Given this list of marker genes TECPR1, ALPK3, MFSD3, ERAL1, H1-2, DYRK2, AIRN, PEMT, DRC3, VIPR1, MTG1, ADCY6, C8orf58, TAF3, HID1, ATXN7L3, CD96, UNC5CL, CYP2D6, SRSF2, RESF1, CHTOP, ARHGEF1, ECM1, CPM, POGZ, GUCY1A1, SRSF12, RNF187, CD86, RNPC3, CPSF6, OAS2, NOTCH4, PDE1B, CISH, C19orf38, CLIC5, CRIPTO, STX1A, OTULINL, PYROXD2, RPS6KA1, RSRP1, GALNT10, UBXN11, KLHL41, NCF1, RCN3, BRD9, TSHZ1, GUCD1 (NCBI Gene Id 83606), NMNAT2 (NCBI Gene Id 23057), ARHGAP9, LYRM7, DNASE1, RASA3, ATG4C, IMP3, REV1, TTYH3, AQR, ZNF629, FAM98C (family with sequence similarity 98 member C), EPB41L1, SBK1, ETV3, TCFL5, BRME1, UST, MYOM1, EYA2, MAGEF1, TPPP, TACC2, SEZ6L2, FCGRT, ZNF764, IMPDH1, ENGASE, KAZALD1, CD5, CA2, USP36, ADD1, BMP5, CRY1, CLDN10, ILDR1, RCBTB2, SPEF2, SETX, GLT8D2, TRAF4, ALDH2, RASGRF2 (Ras protein specific guanine nucleotide releasing factor 2), ITGA6, USP48, BCAT2, SLC25A27, ZNF3, QTRT1, RIPOR1, ARMC10, KCTD12, CD6, TMEFF1, ANKRD44, SIAH1, F2RL1, DGLUCY, PRG4, SLC17A9, GPS2, TRUB1 (TruB pseudouridine synthase family member 1), PPM1B, DNTT, QPRT, BOLL, RFFL, NYAP1, FOXC2, LFNG, UHMK1, CAMK2A, LRRC75B, USP24, RPAIN, CZIB, KLRD1, DRC1, DGKA, PIK3R1, PTGIR, DMBT1, TMEM41A, TMEM64, NFE2L3, IRAG1, FRMD8, TRDMT1, UBQLN4, DENND4A (DENN domain containing 4A), TXNRD3, NOD1, AQP9, TAFA3, ARHGAP15, POLR3B, HOXA1, COL11A2, TANC2, PHYHD1, TMEM59, ABCB11, SELENON, ACSBG1, ORAI2, IL2RA, SGMS1, CAMTA1, RANBP6, SFN, RASGRP1 (NCBI Gene Id 10125), SLC22A2, IL4R, ZNF274, SLC35C1, PATZ1, SHE, AKT3, SAXO4, SMUG1, PLAT, TBC1D16, CCDC82, CFAP251, TMEM68, TMEM71, ADGRG3, CUEDC2, GFOD2, DDX19B, GGT1, FRMD6, RHOBTB2, HEATR5A, GCOM1, APBB1IP, RPRD1A, CCR9, TEC, SNHG7, ARHGEF33, ARHGAP17, MMP11, DCTN6, POLR3E, ACOXL, ZNF397, here is a description of the gene set: species: Homo sapiens Human Gene Set: GSE5679_PPARG_LIGAND_ROSIGLITAZONE_VS_ROSIGLITAZONE_AND_RARA_AGONIST_AM580_TREATED_DC_DN Our data indicated that activation of the PPARg nuclear receptor induces a retinoid response in human dendritic cells. In order to assess the contribution of retinoid signaling to the PPARg response we decided to use a combination of pharmacological activators and inhibitors of these pathways. Cells were treated with the synthetic PPARg ligand rosiglitazone (RSG), or with RSG along with the RARa antagonist (AGN193109) to block RARa mediated gene expression, or the RARa specific agonists (AM580) alone. This design allows one to determine if retinoid signaling is a downstream event of PPARg activation and what portion of PPARg regulated genes are regulated via induced retinoid signaling. Genes down-regulated in monocyte-derived dendritic cells: rosiglitazone versus rosiglitazone and AM580. from publication Szatmari I, Pap A, Rühl R, Ma JX, Illarionov PA, Besra GS, Rajnavolgyi E, Dezso B, Nagy L (PMID 16982809)